The following is a description of a gene set: Mouse Gene Set: GOBP_POLAR_BODY_EXTRUSION_AFTER_MEIOTIC_DIVISIONS studied in species Mus musculus The cell cycle process in which two small cells are generated, as byproducts destined to degenerate, as a result of the first and second meiotic divisions of a primary oocyte during its development to a mature ovum. One polar body is formed in the first division of meiosis and the other in the second division; at each division, the cytoplasm divides unequally, so that the polar body is of much smaller size than the developing oocyte. At the second division in which a polar body is formed, the polar body and the developing oocyte each contain a haploid set of chromosomes., and this is the list of marker genes: Mei1, Spire1, Plk1, Spire2, Washc1, Fmn2, Orc4, Washc5